Given this list of marker genes CARD11, CD28 (CD28 molecule), SASH3, LGALS9, GATA3, SMAD7, EP300, BCL6, IL12RB1, SHB, IL12B, LGALS9C, RC3H2, IL23A, IL2, IL27, RUNX3, SOCS1, PRKCZ, RARA, HLA-DRA, IL18, SH3RF1, MIR21, CD80, BRD4, LGALS1, FOXP3, ITCH, RUNX1, ARG2, HLA-DRB3, NFKBIZ, JAK3, CD274, LOXL3, TWSG1, IFNG, CD69, AGER, GPR65, ZC3H12A, PRKCQ, TBX21, XCL1, BATF, TARM1, IL2RA (NCBI Gene Id 3559), KCNK18, NCKAP1L (NCBI Gene Id 3071), KLHL25, IL2RG, CD86, HLA-DRB1, CD160, CBLB, IL4R, LGALS9B, HLX, NDFIP1, ASCL2, IL23R, VSIR (NCBI Gene Id 64115), RIPK2, NLRP3, TNFSF18, IRF4, NFKBID, CD55, CBFB, ZBTB7B, STAT5A, CD3E, RC3H1, CCL19, OPA1, SOCS5, CD81, MALT1, TNFSF4, ANXA1 (annexin A1), TGFBR2, BRD2, HMGB1, JUNB, CD83, here is a description of the gene set: Human Gene Set: GOBP_REGULATION_OF_CD4_POSITIVE_ALPHA_BETA_T_CELL_ACTIVATION species: Homo sapiens Any process that modulates the frequency, rate or extent of CD4-positive, alpha-beta T cell activation.